The following is a description of a gene set: studied in species Mus musculus Mouse Gene Set: GOBP_POSITIVE_REGULATION_OF_TRANSFORMING_GROWTH_FACTOR_BETA_PRODUCTION Any process that activates or increases the frequency, rate, or extent of production of transforming growth factor-beta., and this is the list of marker genes: Xcl1, Cd200, Myb, Serpinf2, Serpinb7, Bmpr1a, Cd46, Lum, Foxp3, Wnt11, Atf2, Ptgs2, Thbs1, Creb1, Smad3, Fermt1, Atp6ap2, Ifnb1, Cx3cl1, Psg22